Given this list of marker genes DLX2, PIK3CD, HDHD5, ENTPD5, RASSF2, LRRC17, DNMT3B, ST8SIA1, PLCXD2, RPS5, DNAJC3, CHPT1, HS6ST3, MBP, ARMCX2, SLC11A2, LRRC8A, BTLA, CRTAM, SLC26A11 (NCBI Gene Id 65011), AP3M2, THAP11, CEACAM18, ZNF512B, SATB1, PPTC7, TBC1D4, CALHM6, DSE, COMMD8, MIB2, EEFSEC, PDCD2, KLRD1, NOD1, PDLIM5, PDE3B, AP4B1, MBOAT1, IGF1, PRRG1, ELK4, RBM38 (NCBI Gene Id 55544), FAM78A, MRPL58, BCL2L11, STX17, TTLL12, MAFK, IL17RA, PECAM1, TIMM10, GPR18, PHF21A, ECEL1, COMP, IRF9, REEP2, TMEM203, PEX5, LY75, ACTN1, DPP4, UMOD, ITPR1, DAPL1, CD3D, DZIP1, DGKA, ICAM2, GRAMD2B, ZNRF2, NSG2, ST3GAL1, USP18, PLEKHA1 (pleckstrin homology domain containing A1), IPCEF1, TTC13, TBXA2R, OSTF1, FOXO1, TNFSF8, GYPC, ABTB3, PIM2, DCK, LTB, RNF144A, ZC3H12D, TCF20, ARL4C, MBNL3, SH3KBP1, CACNG8, CRLF3, CD200, CHN1, GPRIN3, RIPOR2, ZSCAN2, EMID1, STK4, PDLIM1, CRYBG2, TNKS2, IL1RL2, NMRK1, MGAT4A, TRAF5, KLF17, CCNJ, MYB, AGFG1, CD22, NDUFA4, EEF1B2, PTPN6, TMEM71, DGKZ, ATP1B1, ABLIM1, SH2D1A, TLE4, SLC37A1, PAG1, CHST15, LANCL3, LAIR1 (leukocyte associated immunoglobulin like receptor 1), KDM7A, SCRN2, TRUB2, FAM131C, ESR1, TBCC, ARID5A, DDX6, SLC20A1, KLHDC4, RFLNB, RPS13, CAMSAP2 (NCBI Gene Id 23271), BZW2, ZNRF1, KLHL3, PJA1, ST6GAL1, VIPR1, STK32A, SSBP2, IFIT2, TAB1, EXT1, IDH2, MACO1, BANK1, EXOC6, IL6R, PVR, GRAP2, AFF3, SPSB1, SNORD35A, ZNF394, LEF1, ATP10A, SP110, TMPRSS9, KLK10, PHF20L1, BICDL1, SCG5, RMDN3, here is a description of the gene set: Human Gene Set: GSE37301_MULTIPOTENT_PROGENITOR_VS_CD4_TCELL_UP from publication Ramirez K, Chandler KJ, Spaulding C, Zandi S, Sigvardsson M, Graves BJ, Kee BL (PMID 22608498) studied in species Homo sapiens Expression profiling of Rag2-deficient Ets1++ and Rag2-deficient Ets1-- mature NK cells and WT bone marrow progenitors, WT T cells, and WT Pro B cells Genes up-regulated in multipotent progenitors versus CD4 T cells.